The following is a description of a gene set: species: Homo sapiens Genes predicted to be targets of miRBase v22 microRNA hsa-miR-4764-5p in miRDB v6.0 with MirTarget v4 prediction scores > 80 (high confidence targets). Human Gene Set: MIR4764_5P from publication Chen Y, Wang X (PMID 31504780), and this is the list of marker genes: SEMA6A, ZHX3, GAS1, PAX9, GLRB, MMADHC, NME1, MTF1, BTD, KLF15, SLC32A1, PDK3, ENDOD1, BCAM, SLC6A5, SIX4, LRRN1, GPLD1, OPRK1, GFRA1, ZNF695, CFAP68, CYP19A1, CLNS1A, RFC3 (NCBI Gene Id 5983, replication factor C subunit 3), NFATC3, ZBTB7C, MRPL34, ZNF420, SYNE2, POMC, PHB1, C1orf116, PATZ1, UBR2 (NCBI Gene Id 255838), FHOD3, GTF2E1, PPM1A, ENTPD7, EVI5, ABHD13, THAP9 (NCBI Gene Id 79725), CHD7, KPNA6, CASK, IFT22, GCOM1, ARK2C, TEAD1, TMEM125, PRKAR1A, RAB7A, RNF24, TMEM86A, CUL4B, PIAS3, ZHX1, CDC16 (cell division cycle 16), PLAG1, CLASP1, DIRAS3, RNF123, ST6GAL2, GGNBP2 (NCBI Gene Id 84160), ENTPD1, CDH23, CD109, SLC16A10, MIER1, RANBP10, C10orf105, FNDC7, POLR2M, TSTD2, PRICKLE2